The following is a description of a gene set: studied in species Homo sapiens Human Gene Set: GOBP_MYELOID_LEUKOCYTE_DIFFERENTIATION The process in which a relatively unspecialized myeloid precursor cell acquires the specialized features of any cell of the myeloid leukocyte lineage., and this is the list of marker genes: CLDN18, IL5, MAFB, CSF2, C1QC, SP3, SBNO2, NPM1, PPARGC1B, LGALS9, IL17A, ACIN1, IL23R, CD109, IL23A, CUL4A, PDE2A, MT1G, LRRC17, KLF10, TF, NKAP, CD74, CLPB, FAM3C, PIK3CD, IL1RL1, CSF1R, CSF1, DHRS2, HSF1, IL15, RARA, FARP2, PRTN3, CTNNBIP1, TNFAIP6, MFSD8, IL25, MAPK14, PRXL2A, IL12B (NCBI Gene Id 7907), MIR125B1, TESC, FOS, IL31RA, CBFA2T3, TNFRSF11B, CCR7, NF1, TAOK3, TOB2, GATA1, CITED2, TFRC, TCIRG1, IFNG, VPS13A, ERFE, UBD, ID2, MIR486-1, CDK6, TRIB1, TLR3, CFLAR, SH3PXD2A, NOTCH2, NRROS, ZBTB46, PRKCA, CEBPB, STAT5A, POU4F2, ATP6AP1, TCTA, BGLAP, EPHA2, CCDC39, ARID3C, GLO1, TMEM64, LILRB4, PPP3CA, CALCR, IAPP, SLC4A2, TSPAN2, DIAPH3, ITGB6, ZNF675, CASP8, THOC5, CCR1, PIAS3, BMP2, FES, KIT, INPP5D, RPTOR, BATF3, EFNA2, CEACAM1, UBASH3B, GPR137, SIGLEC15 (NCBI Gene Id 284266), RIPK1, LIF, FOSL2, MED1, CDC42, CCN4, PIK3R1, CD4, TGFBR2, GPR137B, PARP1, MYD88, NAGLU (NCBI Gene Id 4669), EIF2AK1, RASSF2, LYN, NDFIP1, HCLS1, SNX10, JUN, P2RX5, IREB2, IL20, F2RL1, IRF4 (NCBI Gene Id 4592), TM4SF19, PAFAH1B1, GPR183, CD101, LILRB3, ADIPOQ, POU4F1, TREM2, CTNNB1, CALCA, KITLG, PSEN1, LTBR (lymphotoxin beta receptor), LARGE1, TLR4, PTPN2, SOCS1, GATA3, AP3B1, SRP54, INHA, BBLN, GPC3, FASN, QKI, IL4, JAGN1, SFRP1, MMP9, IL33, L3MBTL3, TAL1, TYROBP, SPIB, EVI2B, HOXA7, FCER1G, CEBPA, MITF, CAMK4, RUNX1, ITGB8, RB1, MYH9, UCP2, NR3C1, PPARG, HAX1, SLC9B2, GATA2, APCS, LEF1, GPR68, TNFSF11, VEGFA, IRF7, IGHE, BATF, FOXP1, TFE3, ZFPM1, ANXA2, BAP1, PIR, BMP4, CSF3, BATF2, GPR55, FADD, DCSTAMP, CCL19, INHBA, GBA1, TMEM178A, SRC, LBR, ZFP36L1, GAB2, CEBPE, IGSF23, OCSTAMP, FBXW7, FAM20C, APP, PLA2G3, MIR223, OSCAR, CREB1, NEDD9, IFT80, OSTM1 (osteoclastogenesis associated transmembrane protein 1), MTOR, FSTL3, LRRK1, TNF, FSHB, VPS54, PDE1B (phosphodiesterase 1B), RELB, HLA-DRB1, CCL3, GAB3, NKX2-3, FSHR, TNFRSF11A, CD81, IFI16, CARTPT, IL34, TRAF6, FBN1, SPI1, NDP, PRDM16, RBPJ, PF4, LILRB1, JUNB, TGFB1, LTF, MIR145, EEIG1, MYC, SIRT1, TLR2